The following is a description of a gene set: species: Homo sapiens Human Gene Set: GTF2E2_TARGET_GENES Genes containing one or more binding sites for (GTF2E2) in their promoter regions (TSS -1000,+100 bp) as identified by GTRD version 20.06 ChIP-seq harmonization. from publication Yevshin I, Sharipov R, Kolmykov S, Kondrakhin Y, Kolpakov F (PMID 30445619), and this is the list of marker genes: GARS1 (NCBI Gene Id 7972), LUC7L2, CPNE1, GPBP1L1, PRDX1, PPP1R10, FAM53C, MIR3190, RPS28, MIR5087, H2AC17, TUBA1B (tubulin alpha 1b), SRSF2, IPP, LINC01029, PPP1R15A, ARL15, SLC3A2, ANP32E, RPL17, AQR, IARS1, DLGAP1-AS2, AGPAT4, ARID1A, RPLP0, PRKAG1, H2AC13, CSPP1, ST7L, AGK-DT, TRAPPC6B, RPRD2 (regulation of nuclear pre-mRNA domain containing 2), NRDC, ATF3, CDKAL1 (NCBI Gene Id 54901), BMS1P4, ARRDC3, STXBP5-AS1, ZNF830, C11orf98, MARCHF7, ANKRD13C-DT, RNVU1-18, MNAT1, RPS20, POLDIP3, RNVU1-34, SMARCAD1, LRP6, SNORD50B, TOP3B, MRPL3, FERMT3 (NCBI Gene Id 83706), RPLP1, RITA1, RNU5A-1, DHX29, TMA16, RFX3, SNORD3A, GDF15, NFAT5, PHLDA1-DT, EIF3A, COMT, AUNIP, CDC25C, RCC1, RNVU1-19, BBS1, RNU4-1, SNORD13, IQCH, FUS (NCBI Gene Id 406232), ANXA1, MCL1, SAV1, NSFL1C (NCBI Gene Id 55968), ERI2, RPL17-C18orf32, BEST1, PIGW, OAZ1, MFSD11 (NCBI Gene Id 79157), ENSG00000273727, RNU2-63P, EME1, ZNF343, KCTD10, RACK1, NR1H3, CCNL1, SNORD54, ATAD2, JUNB, TRMT12, C5orf24, PIGV, HCG14, RNU4-2, TYW5, WDR74 (WD repeat domain 74), RPS9, SNORD118 (NCBI Gene Id 727676), PPP1R8, PXN-AS1, H3C10, RNVU1-25, CDC42, BMERB1, LINC01756, TNPO3, SSR4P1 (NCBI Gene Id 84739), TXNIP, SNORD27, RNU4ATAC, ASH2L, COA1, AP3S2, SNHG5, DDX55, KLLN, RNVU1-21, RNVU1-3, RPL36A, GPATCH4, TOB1-AS1, TMEM242-DT (TMEM242 divergent transcript), TTC4, RNU7-1, ATF6, EIF4A1, TUBGCP3, MIR320A, ZSCAN9, PLEKHM3, ZNF681, RNVU1-15 (RNA, variant U1 small nuclear 15), MYL12A, RMND5B, KAT5, TXNRD2, BRD2, LDLR, MARCKSL1 (NCBI Gene Id 65108), RPL36A-HNRNPH2, SNORD26, EGR1, COPS4, SNHG1, AAGAB, RNU5D-1, SEC22B, BAZ2B-AS1, SLC9A1, IER5, BMS1P4-AGAP5, POU2F3, CITED2, MIR3189, TMEM168, SRP72, SNORD55, HERPUD1, NDUFA7, ENGASE, H1-4 (H1.4 linker histone, cluster member), GTPBP2, ENSG00000272195 (novel transcript, antisense to EFCAB2), SUPT7L (NCBI Gene Id 9913), CALM1, RNVU1-27, CLASP1, SNORD58B, THRB, PDLIM7, GTF2B, C11orf54, RNVU1-6, H2AX, PIH1D1, SNORD95 (NCBI Gene Id 619570), ROCK2 (NCBI Gene Id 9475), RPS8, UBE3B, RNU2-2P, C12orf57, H2BC17, ZSCAN16-AS1 (ZSCAN16 antisense RNA 1), RNF185, COPA, AKR1A1, STK17B, ZNF770, CAPZA1, ZC3H6, RPL41, RNVU1-22, SRSF3, MRPL27, DDIT3, RNVU1-24, BTG1, ORC5, ANKRD40, DNAJB4, ACTG1, LINC00869, CCDC80, H4C8, INTS6, RNU5A-8P, MYLIP (myosin regulatory light chain interacting protein), DDX6, PTEN, RNU5F-1, NDUFAB1, SFPQ, PABPC4, BTG1-DT, RBM12, PPP4C, NEK9, HNRNPH1, RPL37, SNHG17, RAB5A, TANK-AS1, MTERF4, SNORA16A, MPDU1, RNVU1-2A, NFYC-AS1, ANKRD13C, MIR4766 (microRNA 4766), MAF1, TFRC, H2BC26, CSNK1G3, RPS12, ADARB1, REXO5, RNVU1-30, RNF220, VPS25, B3GALT1-AS1, RHOBTB3, TMEM242, H1-3, MAML1, TPI1P2, CCT6B, CSNK1A1, MBD6, ANAPC5, AMD1, RPPH1, SMARCAD1-DT, EIF3G, AGK, GARS1-DT, RPS6, GLUD1P3, CLASRP, UBE2S, AKIRIN2, PTMA (NCBI Gene Id 91418), USE1, RNU5B-1, GIHCG, UQCC6, COPS5, JSRP1, RNVU1-28, NFKBIZ, RPL10 (NCBI Gene Id 88324), GTF3C3, RNU1-1, CHEK1, SNHG12, ZNF397, LINC01732, TUBA1B-AS1, COG4, GTF3C5, RNU11, CERNA3 (competing endogenous lncRNA 3 for miR-645), MRPL35 (mitochondrial ribosomal protein L35), ATF6-DT, INTS6-AS1, GLUL, RNVU1-26, DDX54, RBM34, H4C5, MIR1538, EFHB, MIR142HG, RNVU1-2, MIR3928, NEAT1, LRSAM1, TUBA1C, MAT2A, SF3B3, TTI2, FTH1, MRPL58, H2AC7, DUSP1, H2BC7, TUBB4B, SLC4A1AP, MYO19, GADD45B, ING3, MKRN3 (NCBI Gene Id 7681), SNRPB, MTREX, LINC01719, RNU5E-6P, MKRN2, ZNF93, NCSTN, MRPS18B, NR3C1, ZC3HC1, RFX3-DT, REXO4, ADNP, ZWILCH, ACP2, TRIP11, H2AC25, SKP1, SMIM30, RNU1-2, PPP2R1B, ZSCAN12, BCL2L13, SHARPIN, NFYC, TMEM69, POLR3D, FTL, PCLAF, ZNF621, RPL38 (NCBI Gene Id 6169), PHLDA1, RPL36, SAR1B, TOB1, BRK1, RNVU1-4, SNHG32, DDIT4, RNU5E-4P, MPDU1-AS1, EIF2D, SNHG3, SNORD46, SFT2D3, INTS5, C15orf39, MRPL1, LINC01476, NDUFAF1, CAP1, CPED1, MIR548AW, CSKMT, UBE2L3, SNORA57, TANK, SNORD25, RNU2-17P (RNA, U2 small nuclear 17, pseudogene), SMPD4P1, HNRNPH3, MAIP1, TRIP4, SNHG7, EEF1A1, RNU12, HEXIM1, C11orf24, GFI1B, SNORD48, RNVU1-23, PARP2, RNU5E-1, H3C12, RPL4, SOCS1, TMEM128, ARHGEF37, THRB-AS1, TSC1, H1-2, RPS26, RNU1-108P, GADD45GIP1, H4C3, SRSF7, MYSM1, RPL12, H2BC13, BTK, KLF6, GEMIN6, ACBD6, SNORD101, TAF1D, TIMM17A, HSP90AB1, H4C2